The following is a description of a gene set: An mRNA stabilization process in which one or more RNA-binding proteins associate with the 3'-untranslated region (UTR) of an mRNA. species: Mus musculus Mouse Gene Set: GOBP_3_UTR_MEDIATED_MRNA_STABILIZATION, and this is the list of marker genes: Elavl1, Tent4a, Dazl, Arid5a, Nicol1, Hnrnpa0, Angel2, Ptbp1, Tent4b, Elavl4, Mir466l, Qki, Rbm47, Mapkapk2, Mettl16, Tardbp, Boll, Larp4b, Tirap, Hnrnpc, Myd88, Rbm38, Rbm24, Zfp36, Rbm10